Given this list of marker genes RAB11FIP2, FCGR1BP, CYB561A3, SLC5A7, ANP32E, SLC11A1, RHOBTB2, VPS25, RBSN, LDLR, MVB12B, SNX10, PIP4P1, GRB14, STX7, HLA-DPA1, VPS39, TPCN1, TSG101, TLR7, EPHA4, TPCN2, SORCS2, AP1G2, LDLRAD4, SPPL2A, SLC6A4, ATP13A4, TMEM59, ANXA6, ITM2B (NCBI Gene Id 9445), GGA1, RAB11FIP5, LEPROT, PLA2G4B, LAMP2, ABCA7 (NCBI Gene Id 82843), TOM1 (target of myb1 membrane trafficking protein), FZD5, FIG4, TMEM9, GRIA1, FLT3, RAP2A, SNX21, PLEKHF2, RFFL, RAB7A, SCAMP2, HLA-DRB1, RAB11A, ZDHHC2, CC2D1A, INPP5F, ATP6V0C, CLVS2, PSEN1, ERBB2, CHMP4C, NDFIP1, ATP7A, RAB27B, TRAF3, SNX1, SH3GL1, TF, YIPF2, DTX3L, RHOU, ARHGAP1, IFITM3, TMEM63B, CLTC, NEU3, AMN, SLC11A2, ATP11C, ATP6V0A2, CFTR, CHMP4BP1, CHMP7, ATP6V0E1, ATP6V0D1, GPR135, MCOLN1, SLC9A7, THSD1, VPS37A, GNPNAT1, SLC30A3, HLA-DPB1, DIAPH3, PLEKHB2, ANTXR2, SLC26A7, FCGRT, RHOBTB1, ATP9A, NDRG1, ZDHHC11, STEAP3, SLC15A4, CAV1, PI4K2A, TASL, DNAJC13, ATP6AP1, ACAP2, ANKFY1, SNX12, KIF16B, UBB, ABCA2, VPS45, EHD1, GGA3, SYT11, MITD1, SLC30A4, ENTREP1, ATP6V1A (ATPase H+ transporting V1 subunit A), ZFYVE28, PDLIM4, PLA2G4E, RAB5C, EPS15, REP15, BOK, PRAF2, SPAAR, CLIP3, AP3D1, PIP5K1C, MTMR2, VPS41, SLC1A1, HLA-DQB1, WASHC1, CHMP4B, MYD88, TMEM163, YIPF1, HLA-DOA, HLA-DMA, ANXA8, MYO1B, HLA-DQB2, ABHD6, IRAK4, CMTM6, RAB12, PLIN3, LAPTM4B, ABCA3, HLA-G, GOSR2, WNT3A, ARL8A, SLC38A9 (solute carrier family 38 member 9), DTNBP1, CHMP2B, UBC, SPG21, RHOB, GGA2, PLPP2, SNX16, SLC9A6, NDFIP2, SLC9A9, FGD2, ITCH, PLD3, RET, HTR4, CD164, MKLN1, SYT5, MARCHF8, RAB5A, CHMP5, GRIPAP1, RHOV, VPS28, AKAP5, USP8, CD300LG, LAMTOR5, VPS13C, SORT1, KCNK6, ZFYVE9, VPS35, RHOD, CHMP2A, FCGR1A, VPS33B, RPS27A, SNX5, ATG9A, ANXA2, TYRP1, ARL8B, RABEPK, BACE1, MON2, SNX18, TICAM1, ATP6V1F, SPNS2, ATP6V1D, RAB22A, ATP13A2, DKK1, MVB12A, CD14, VTI1B, PMEPA1, SNX13, MARCHF1, SH3GL3, ABCA5, NCF4, HLA-H, EGFR, CC2D1B, SORL1, BAIAP3, RNF167, VPS13A, CD63, NOTCH1, FURIN, RMC1, AP5S1, CHMP1A, KREMEN2, DAGLA, PLEKHM2, SCAMP3, ATP8A2, SLC29A3, TMEM106B, OCA2, FZD7, TMEM30A, COMMD1, PIP4P2, CD8B, SLA2, CD68, SNX14, TMEM150B (NCBI Gene Id 284417), ARHGAP10, UBXN6, TBC1D3 (NCBI Gene Id 729873), ATG9B, STOML1, RILP, SPHK1, SCYL2 (SCY1 like pseudokinase 2), SLC46A2, LAMP1, CTSD, ABHD17B, ZNRF2 (zinc and ring finger 2), AP2S1, SCAMP5, ARHGAP26, PIKFYVE, ADRB2, RAB8A, FFAR4, VAMP8, HLA-DQA1, TMEM184A, VPS11, IRF7, SLC46A1 (NCBI Gene Id 113235), EEA1, VPS18, SLC35D3, DIO3, AP2M1, WASH3P (NCBI Gene Id 374666), STEAP4, ABCB6, PCSK9, LLGL1, RAB14, CX3CR1, ATG16L1, LY96, NAPEPLD, CD274, RAC1, UEVLD, SNX6, SNX8, HLA-DRB4, UBA52, INPP5B, SLC9B2, HLA-E, NUMB, RAP2C, SNX2, TSPAN15, SLC31A1, WASHC3, GPR65, VAMP4, INPP4A, EHD2, TCIRG1, RAB31, HLA-DOB, SPPL2B, CD1B, TMEM108, PLEKHM1, IGF2R, SCAMP4 (secretory carrier membrane protein 4), CLCN3, ZFYVE27 (NCBI Gene Id 118813), RABGEF1, NPC1, APP, ATP6V0A1, ATP6V0A4, RAB21, TAB1, HLA-DRA, SNX20, EHD3, TRAF6, ABHD17A, TLR4, STEAP1 (STEAP family member 1), SUN2, APPL1, PML, CLTA, ZMPSTE24, SNX30, OCRL, SLC26A9, HLA-DQA2, SNX4, HLA-F, ATP6V0E2, RAB8B, LAMTOR2, TMEM45B, CDIP1 (cell death inducing p53 target 1), PSENEN, RAB27A, RAB15, RAB7B, VPS37D, VAC14, STEAP2, TLR8, HLA-DRB5, LAMTOR4, LAPTM4A, GPR62, ZFYVE16, CLVS1, MFSD8, ARF6, CHMP1B (NCBI Gene Id 57132), UBE2D3, VPS29, MR1, GOLIM4, VPS33A, RAB11FIP3, HPS6, VPS52 (NCBI Gene Id 6293), OSBPL6, NSG2, KIF13A, CD1D, ATP10B, PDIA3, VPS4B, ATP13A5, KIAA0319, SLC31A2, APH1A, GPNMB, ATP6V1H, VTI1A, RAP2B, TMEM165 (transmembrane protein 165), ATP6AP2, CD1C, KCNH1, ELAPOR1, RUFY1, CLEC16A, SNX17, SLC30A10, MMGT1, TMBIM1, STX6, RAB4B, VPS53, TMEM9B, APH1B, TM9SF2, STARD3NL, VOPP1, PACSIN2, HLA-A, SNX19, ATP6V0D2, NCSTN, ATP6V0B, SLC48A1, WDR81, ABCB11, AP2A1, VPS4A, PLD1, HLA-C, STAM2, EHD4, VPS36, GALNTL5, APOB, LAMP5, RAB23, GIMAP5, IRGM, RNF144A, WASHC5, CD207, OR51E2, RAP1A, TAB2, IFITM2, SBF2, ABCC5, VAMP7, TFRC, ANXA1, MICALL1, RNASEK, EPHB1, VPS13B, TMEM175, STAM, OSBPL9, CHMP4A, RAB10 (NCBI Gene Id 51140), SNX25, TLR3 (NCBI Gene Id 7098), NCL, MCOLN3, MMD, BECN1, WDR44, WDR83, ZDHHC1, NSG1, RCC2, ACAP1, TICAM2, SNX3, HLA-DMB, STARD3, SLC39A4, CLEC10A, VPS37C, SCAMP1, TAB3, CPTP, WASHC2A, UBAP1L, MICAL1, OSBPL11, HLA-B, CLN3, STX12, MRC1, TOM1L1, DOP1B, RAB5B, CLCN4, RAB13, SNF8, RAB35, MTMR4, SYNDIG1, VAMP3, UBA1, CHMP6, CLCN6, SLC15A3, RAB4A, CD1A, DCSTAMP, UBAP1 (ubiquitin associated protein 1), INSR, B2M, AQP4, RNF13, SLC30A2, SLC36A2, IRAK2, ARHGAP32, NCDN, NTRK2, APPL2, TLR9, NTRK1, DYNC1LI1, PARM1, WLS, HLA-DRB3, LRP6, WASH6P, SLC9A3, RAB17, ABHD17C, ATP13A3, AP2B1, LZTR1, MCOLN2, ARC, RAB11FIP4, PMEL, RABEP1, MARCHF3, AP5M1, OPTN, SLC9A5, EPHA8, TMEM63A, SLC39A14, VPS16, VPS26A, ADAM30, SNX7, SLC9A8, PI4K2B, GPR61, LAMTOR1, WIPI1, MARCHF2, SNX27, RAB11B, MREG, VPS37B, MAPKAP1, ECE1, ATP11B (ATPase phospholipid transporting 11B (putative)), MAP3K7, HSD17B6, LAMP3, PLEKHF1, TBC1D5, WASHC4, IRAK1, WDR91, CHMP3, LAMTOR3, AP2A2, ITGB1, CORO1C, SCARB2, ABCG4, LITAFD, RIPK1, LITAF, KIR2DL4, CLCN5, ANTXR1, FCMR, HGS, VTA1, WASHC2C, here is a description of the gene set: Human Gene Set: GOCC_ENDOSOME_MEMBRANE The lipid bilayer surrounding an endosome. species: Homo sapiens